The following is a description of a gene set: Genes containing one or more binding sites for (PTPRA) in their promoter regions (TSS -1000,+100 bp) as identified by GTRD version 20.06 ChIP-seq harmonization. studied in species Homo sapiens Human Gene Set: PTPRA_TARGET_GENES from publication Yevshin I, Sharipov R, Kolmykov S, Kondrakhin Y, Kolpakov F (PMID 30445619), and this is the list of marker genes: FAM161A, VPS37B, MRPL3, RAD1, BCL2L13 (NCBI Gene Id 25779), RABGGTB, RPS14, KLHL9, RNU6-1, PAPPA2, DROSHA, NPR2, GNAS, NUP205, RNA5SP215 (NCBI Gene Id 100873475), CIRBP, NUP85, PYGO2, IQCH-AS1, AP3M1, LINC00616, SPRING1, HTR5A, BARHL1, DDX3X, PGK1, GLRA1, PHF6, C17orf113, LINC01399, APPBP2-DT, ADGRB3, HIP1R, SNAP25-AS1, ZFP2, NHLH1, C1orf43, RNVU1-14, PNPLA6, TMEM117, YTHDF2, MGST3, CCDC159, FLAD1, IL10RA, MIR7-3, ZNF764, AGBL5-AS1, ATXN7L2, GSPT1, TXN2, MFSD3, OLFM1, CPLX2, GCFC2, MEN1, MAPK8IP2, MIR7-3HG, IER5, GATA1, XRN2, TUBA5P, TMED9 (transmembrane p24 trafficking protein 9), CCDC18-AS1, ITGB1BP1, MICAL3, MSMP, LINC02564, MRPS10, GDPD5, PSMB4 (NCBI Gene Id 5692), EMSY, ZNF75A, RPS29, LINC01641, TMEM147-AS1, MICB, MRPL1, LRRC27, CDC123, SYN3, FNDC5, ZFX, TTLL5, COX6B1, PREX1, RPS6, MDC1, RNFT2, AMPD3, RNA5SP60, RNA5SP453, CD160, HDGF, SESN2, TUG1, ATP6V1E1, CYP4F2, KREMEN1, CCDC28B, PRCC, SPICP5, MTR, KRT36, MTA3, ZFX-AS1, ARMCX5, CCDC107, EMSY-DT, SNORD45C, ATP6V0A1, MIR184, DR1, ZNF397, TTC9B, KCNG3, LTV1, SYNGAP1, CWF19L1, RAB3GAP2, INKA2, UBAP2L, APPBP2 (amyloid beta precursor protein binding protein 2), AGBL5, BRIX1, SCRT1, CIRBP-AS1, PRKCH, PPP1R8, C15orf61